The following is a description of a gene set: species: Homo sapiens Any process that modulates the frequency, rate or extent of the immune response, the immunological reaction of an organism to an immunogenic stimulus. Human Gene Set: GOBP_REGULATION_OF_IMMUNE_RESPONSE, and this is the list of marker genes: NPY5R, KLRC2, CCL19, C1QB (NCBI Gene Id 713), ADA, KLRD1, HLA-A, NFKBIA, UFD1, SLC39A6, LIME1, TICAM2, BANK1, TIFA, ZDHHC12, MAP2K7, YTHDF3, PIK3CA, LAT, MAPK14, FCGR2C, GDI1, HLA-H, MYO1G, CARD11, NMI, SIRT2, SIN3A, IGKC, TYROBP (NCBI Gene Id 7305), DDX39A, CD300LD, FOXP1, IL12RB1, ELP6, CD1C, RC3H1, IL20RB, GPR32, NOS2, SIRT1, LILRA6, FBXO38, LGALS1, IL21, MKRN2, LRCH4, CD2AP, INPPL1, IL6, OAS1, TRIM62, CD200, TLR4, PIK3R6, KLRB1, SERPING1, ITGAM, ALPK1, IRAK3, TNF, IL1B, RNF31, FCGR2A, SMAD3, SPI1, CD247, IGHA1, C8G, CASP8, TAB1, TLR10, MEF2C, BTN2A3P (NCBI Gene Id 54718), KIR2DS1, KIR2DS5 (NCBI Gene Id 3810), MICB, GPR33, MAPK3, TRIM5, ZNFX1, IGHM, NFKB1, IL1R1, TNFSF13, TRAT1, ZC3HAV1, FADD, BAX, PAK3, ZNRF4, LAG3, ZDHHC18, YWHAG, BRD2, TYK2, TNFSF13B, TRIM11, CD3E, CD3G, KIT, IL4I1, ANXA1, STAT5B, GATA3, ZDHHC5, ZDHHC1, CD81, OGT, MAPKAPK2, MUL1, GBP2, NLRP2B, SIVA1, PTPN11, EIF2B4, STMP1, CD8B, YWHAE (NCBI Gene Id 7531), LBP, SQSTM1, CD1D, SLAMF6, HSPA1B, C7, PPP3CB, SUSD4, GIGYF2, MMP12, BTNL2, DAB2IP, IGSF1, GRN, FCAR, INPP5D, ATG5, TRIM32, IRAK4, KIR2DS2, C1QBP, BTK, NFATC2, NLRP4, INAVA, ATAD5, IL18R1, IL12B, IL2, SOS1, MOG, HLA-E, RELA, TGFB2, SHLD3, PTPN6, ASCL2, PGC, CD7, RPS6KA3, RASGRP1, CD80, TRGC2, FCRL3, LETMD1, LATS1, HLA-DQB2, MARCHF5, LRP8, NAGK, CD4 (NCBI Gene Id 920), TICAM1 (TIR domain containing adaptor molecule 1), CD47, XBP1, C3AR1, BCL6, PDE4D, EP300, BCR, XRCC5, LILRB1, CD1E, PSMA1, C1QA, RAET1L, CD96, PAXIP1, SPHK2, GRAMD4, CD79B, INS, PTPN22, STAT5A, KHDRBS1, CLCF1 (NCBI Gene Id 23529), RNF135, ISG15, PYDC2, DDX60, RAB7B, LILRB2, KIR2DS3, WNK1, RNF170, MIR520B, PPP6C, PARK7, PRNP, NCR3, ABHD17A, IGHG4, PDCD1, RIGI, TASL, PSG9, XIAP, IGLC6, OLFM4, LSM14A, OTOP1, GBP5, HRAS (HRas proto-oncogene, GTPase), UBQLN1, HMGB1, LILRB5, STK11, SPPL2B, RC3H2, CD8B2, KMT5B, TFRC, PRAM1, EVPL, CD8A, MAP3K7 (NCBI Gene Id 6885), PTPRJ, PPP2CA, CD300A (NCBI Gene Id 11314), BTN2A1, FYB1, TIRAP (NCBI Gene Id 115469), CYLD, VAV1, PLPP4, MAPK8, ZNF683, CCR7, FCGR2B, TRAF2, TNIP1, CTSH, TOMM70, PARP1, NCK1, WNT5A, RASGRP4, ANKRD17, PRKDC, COLEC10, EPG5, CLPB, TTLL12, POLR3B, STOML2, SYK, IRF5, ERAP1, ZC3H12A, CLEC6A, KLHL6, LRRC19, SECTM1, IL17F, GP6, VTCN1, LAIR2, ZP3, TAX1BP1, THEMIS2, WDFY1, IL4, TRIM31, SLA2, DUSP22, TRPM4, EXOSC6, IGHG1, MIR19B1, CD226, SERPINB4, BTNL9, BTNL3, BANF1, CD1B, PARP14, CD79A, SLAMF1, CD300H, ZCCHC3, TAP2, THY1, BRD4, MAP2K6, RAB11FIP2, RNF125, SH2B2, CARD10, S100A9, DUSP3, CARD14, PVR, FCGR3A, CD40, MAP3K1, SPPL2A, IKBKE (inhibitor of nuclear factor kappa B kinase subunit epsilon), LYPLAL1, PIK3CD, LAMP2, IDO1, WASHC4, PVRIG, HMCES, SASH3, BTN2A2, KLRC4, CD160, CD200R1, MIR140, CLU, PIK3AP1, KLRC1, PRKCE, C1S, MAD2L2, TBX21, TRGC1, IFIH1, P2RX7, FCN3, GPR31, GPX1, SH2D1B, MASP2, KLRC4-KLRK1, FPR2, AP3B1, PQBP1, FCGR1A, MAPK1, NINJ1, MIR149, MASP1 (NCBI Gene Id 5648), DRD2, COLEC11, BCAR1, CADM1, TRIL, KMT5C, STX7 (NCBI Gene Id 8417), SLC11A1, HCK, LYAR, HRG, RSAD2, CD14, UBASH3A, LCP2, PPP2R3C, KCNJ8, UBE2K, C5AR2, CD24, BLK (NCBI Gene Id 84743), AZGP1, MALT1, NONO, PELI1, TNIP3, MAVS, CBLB, CD86, SLC15A2, C9orf72, CTLA4, IGHG3 (NCBI Gene Id 3502), CEP63, PLSCR1, CD74, FOSL2, LAX1, CLEC12A, PARP3 (poly(ADP-ribose) polymerase family member 3), YWHAZ, FCRLB, HLA-DQB1, ESR1, AHR, PAK2, RBCK1, CD5L, XRCC6, NR4A3, TRAF3IP3, GSDME, POLR3D (NCBI Gene Id 661), PLD2, LGR4, RARA, HDAC6, PTK2, MIR19A, HLA-C, PHB2, A1BG, IL23R, FZD5, CXCL13, ATG12, C5AR1, CLEC4E, HLA-G, TP53BP1, PTPN2, MIR146A, CDC37, RHBDF2, TLR8, CFB, KIR3DL2, FGL1 (fibrinogen like 1), EIF2B2, IKBKB, LAIR1, LOXL3, BTN3A3, C6, ICOSLG, CD36, PRKCB, IFI16, PRKD2, TBK1, APPL2, CD72, BLNK, A2M, PHB1, MIR136, FYN, DTX4, PIK3R1, CREBBP, C4A, BCL2, FUT7, FCER1A, CLEC12B, MAP2K4, USP17L2 (ubiquitin specific peptidase 17 like family member 2), NFKBID, DDX3X, TLR2, EREG, AURKB, ULBP2, EZR, ALOX15, SELENOS, FCGR1BP, BECN1, VSTM1, OTUD5, CLNK, PDPK1, RNF34, CD300LF, MNDA, IFNK, PUM2, FAM3A, PTPRC, POLR3G, DGKZ, PLCL2, PTPRD, PGLYRP2, LTA, NSD2, ZBTB7B, AMBP, N4BP1, TRIM21, YTHDF2, ITPRIPL1, PPT1, STING1, DHX33, HLA-DRB5, FCGR3B, LILRA3, GPR65, TRAC, CFHR3 (complement factor H related 3), PLA2G2D, MICA, LILRA1, SMCR8, IL18RAP, IRAK2, PIANP, ENPP3, SAMHD1, GCSAML, TLR6, MATR3, MIR18A, THEMIS, BIRC2 (NCBI Gene Id 329), SCIMP, EIF2B5, LCK, BTLA, SOCS5, SMIM30, KAT5, ULBP3, MEFV, IRF1, CLEC4D (C-type lectin domain family 4 member D), AARS2, USP18, PGLYRP3, NCF1, KIR3DL1, HLA-B, CSNK1A1, CTSS, EIF2AK4, HMGB2 (high mobility group box 2), NLRP1, ENTPD7, SPN, SPINK5, IL7R, IL33, HEXIM1, MIR21, RTN4, PLA2G4A, CARD9, LPXN, RNF39, YES1, HLA-DRB1, EIF4E2, KCNN4, PLEKHA1, IGLC3, EIF2B3, POLR3C, HLA-DQA2, IL12A, USP27X, CD38, IPO5, IL27RA, TARM1, DNASE2, SUPT6H, JUNB, SHLD1, CD55, CSK, CD3D, ATAT1, FFAR2, TNFSF18, RNF115, CEACAM1, TIGIT, EPHB2, FCN2, HHLA2, COL3A1, HMSD, LILRB3, DHX58, HFE, NPLOC4, ZNRF1, MIR200C, ACOD1, CD28, IGHA2, LIPA, PLA2G5, VSIG4, WDR41, GFI1, TLR7, HLA-DOB, AKT1, IL6ST, FPR1, NFE2L2, ITGB2 (integrin subunit beta 2), OTUD4, TNFSF4, ITK, FPR3, FLOT2, C9, ZDHHC4, COLEC12, HCST, VAV3, IL18, SPPL3, HSPA8 (heat shock protein family A (Hsp70) member 8), SLC19A1, BCL10, IGLC1, LACC1, NAIP, PAK1, SPG21, AGER, CGAS, LAT2, PPARG, PLA2G6, ADAR, ZDHHC9, NFKBIL1, IRF7, CCL5, DNAJA3, CD33, IL15, KIR2DL2, NR1D1, PDE4B, IGHG2, ARG2, FBXL2, ARRB2, NDFIP1, BPIFB1, SFPQ, PRKCH, PSPC1, HCFC2, APPL1 (adaptor protein, phosphotyrosine interacting with PH domain and leucine zipper 1), CMTM3, LAPTM5, SMPDL3A, IRAK1, CLEC7A, IL1RL1, PKN1, ELF1, CFI, MYD88, CASP1, NLRP3, CD300C, BTRC, APLF, F2RL1, STX4, KIR2DL4, HSP90B1, C4BPB, TNFRSF14, C3, AKIRIN2, CAV1 (NCBI Gene Id 857), USP15, CLEC4G, ULBP1, DENND1B, CR1, C2, CYBA, C1R, ECSIT, HPX, ARID5A, TRIM3, SCARA3, KLRK1, STAT6, HLA-DRB4, FYB2, SLAMF8, KIR2DL5A, RPS3, OASL (2'-5'-oligoadenylate synthetase like), LIMK1, TRIM41, OTULIN, PYDC5, ZBTB1, ADAM8, REG3G, HLA-DPA1, PIGR (polymeric immunoglobulin receptor), CRTAM, SLC15A3, CHUK, KIR3DL3, NLRC4 (NCBI Gene Id 58484), TNFRSF1B, LILRA4, DDRGK1, HLA-DMA, TLR3, HLA-DRA (NCBI Gene Id 7930), MAPK10, CFH, TRAF3, UBR2, RBM47, FCHO1, HAVCR2, S100A14, CD274, RIPK3, NOP53, CFHR5, TMIGD3, TRIM27 (tripartite motif containing 27), IRGM, CLC, MIR520E, TRIM25, NLRC5, KLK7, SPSB3, BRAF, APP, CACTIN, S100A8, C8B, PTPRS, HLA-DMB, CD300E, GPS2, TNFAIP3, NOD1, TARBP2, MARK4 (NCBI Gene Id 57787), LGALS9, FLOT1, NECTIN4, PYCARD, SEC14L1, LTF, SLC46A2, FKBP1A, CPTP (ceramide-1-phosphate transfer protein), CFD, MFHAS1, CD69, GPR32P1, MIR6869, PYDC1 (NCBI Gene Id 260434), IFNG, MR1, TRBC2, FCMR, FCER1G, RFTN1, C17orf99, RIF1, USP50, C4BPA, LAMP1, EXOSC3, NAGLU, SH2D1A, CACNB4, MIR302E, RAET1G, CD59, PIM1, SMPDL3B, GPATCH3, C1RL, HLX, TRIM15, NFKBIZ, PLK2, KCNK6, ZDHHC3, CCDC134, CCR2, KLK3 (NCBI Gene Id 90446), CR1L, GBP1, TREX1, PUM1, BIRC3, TRAF6, PAWR, CASP6, HLA-DPB1, OAS3, IFNL1, PRKD1, IRF3, GPR108, KIR2DS4, TKFC, SLC22A13, IFI35, KLK5, NPY, STAP1, SMAD7, IL27, BAG6, ECM1, MIR20A (NCBI Gene Id 406982), PLA2G1B, SHLD2, APOE, DDX41, SHB, USP5, IFNL2, HLA-DOA, SLC15A4, IKBKG, TRIM65, PRKCD, HSP90AA1, ERBIN, MAPKAPK3, RAP1A, RGCC, NLRX1, IGHD, POLR3F, NCR1, UFL1, IL23A, NOD2 (NCBI Gene Id 8135), AP1G1, CFHR4, SLC39A10, MBL2, ZP4, PSMB4, PGLYRP1, BATF, PARP9, TGFB1, UBE2N, HLA-DQA1, BTNL10P, METTL3, RPS19, MS4A1, KIR3DS1, CD37, PRKCZ, BTN3A2, LRRC14, IFNL3, TRDC, TMEM126A, HLA-DRB3, RAB29, MIR34A, IGHE, ZBP1, UNC93B1 (NCBI Gene Id 81622), GPR151 (G protein-coupled receptor 151), ARG1, LY96, KCNK13, PSEN1, CACNB3, CYRIB, MIR210, GPR17, LYN, FER, RNF185, MIR181B1, CARD8, FOXJ1, TEC, VSIR, IFNL4, CMKLR1, KIR2DL5B, SAMSN1, FGL2, NECTIN2, CRK, KARS1, NR1H4, JAK2, IFNA2, PLCG1, KIR2DL3, LILRB4, GNAS, CD46, STAT2, TLR5, CFHR2, RBM14, WAS, TRAFD1, MIR105-1, JAK3, NCKAP1L, GCSAM, C1QC, FOSL1, TNFRSF21, IGLC7, DUSP10, RNF144A, USP38, FCER2, USP29, TRIM56, GATA6, TLR1, PLCG2, SFN, FCN1, CD276, EIF2AK2, SERPINB9, OPA1, OSCAR, PRKCQ (protein kinase C theta), KLRC3, LEP, IL17A, LGALS3, TIFAB, NR1H3, BRCC3, EIF2B1, B2M, NLRP10, KIR2DL1, CFP, TLR9, GRB2, TRBC1, SARM1, CTSG, BTN1A1, IFNB1, RIOK3, MAPK9, BTN3A1, MLH1, TSPAN6, IL10, CD19, KIR3DX1, CD300LB, MIR4691, LILRA2, CD1A, PJA2, ABL1, TYRO3, CD177, GKN2, AIM2, TREML4, C4B, DCST1, TRIM6, NFAM1, BMX, SKAP1, TREM2, SRC, VAV2, PRKAA1, PYHIN1, FOXP3, ABHD8, PCK1, CR2, CPT1A, HSPD1, CALHM6, XCL1, NLRP6, RAET1E, NLRC3, FURIN, HLA-F, KRT1, TNIP2, CD22, TESPA1, PCBP2, RABGEF1, CFHR1, FGR, BTNL8 (butyrophilin like 8), IRF4 (NCBI Gene Id 4592), NEK7, C8A, RIPK2, LATS2, LILRA5, ITCH, ERMAP, MED1, NR1H2, ZAP70, TXK, MIR17, HSPA1A, GPLD1, PMS2, MIR708, ELANE, PHPT1, SPNS2, PTPN1, MIR200B, KLHL22, IL4R, CNOT7, ADCY7, C5 (complement C5), CRKL, MSH2, DHX9